Given this list of marker genes BCAN, BGN, CSPG4, CHST14, VCAN, NCAN, DCN, CSPG5, here is a description of the gene set: Carbohydrate sulfotransferase 14 (CHST14 also known as D4ST-1) mediates the transfer of sulfate to position 4 of further N-acetylgalactosamine (GalNAc) residues of dermatan sulfate (DS). Defects in CHST14 cause Ehlers-Danlos syndrome, musculocontractural type (MIM:601776). The Ehlers-Danlos syndromes (EDS) are a group of connective tissue disorders that share common features such as skin hyperextensibility, articular hypermobility and tissue fragility. The musculocontractural form of EDS (MIM:601776) include distinctive characteristics such as craniofacial dysmorphism, congenital contractures of fingers and thumbs, clubfeet, severe kyphoscoliosis and muscular hypotonia. studied in species Homo sapiens Reactome Pathway: Defective CHST14 causes EDS, musculocontractural type part of: Diseases associated with glycosaminoglycan metabolism